Given this list of marker genes IL23R, NKX6-2, OPA1, IL12RB1, BRD4, MIR206, MIR1-1, BRD2, SPDEF (NCBI Gene Id 25803), IL23A, FGF2, MIR208A, EP300, MIR133A1, WNT3A, IL12B, here is a description of the gene set: Any process that activates, maintains or increases the frequency or rate of cell fate commitment. Cell fate commitment is the commitment of cells to specific cell fates and their capacity to differentiate into particular kinds of cells. Positional information is established through protein signals that emanate from a localized source within a cell (the initial one-cell zygote) or within a developmental field. Human Gene Set: GOBP_POSITIVE_REGULATION_OF_CELL_FATE_COMMITMENT species: Homo sapiens